The following is a description of a gene set: Genes up-regulated in comparison of dendritic cells (DC) stimulated with LPS (TLR4 agonist) at 0.5 h versus those stimulated at 12 h. Human Gene Set: GSE17721_0.5H_VS_12H_LPS_BMDC_UP mouse primary BMDCs were stimulated with tlr ligands and gene expression changes were profiled on Affymetrix arrays studied in species Homo sapiens from publication Amit I, Garber M, Chevrier N, Leite AP, Donner Y, Eisenhaure T, Guttman M, Grenier JK, Li W, Zuk O, Schubert LA, Birditt B, Shay T, Goren A, Zhang X, Smith Z, Deering R, McDonald RC, Cabili M, Bernstein BE, Rinn JL, Meissner A, Root DE, Hacohen N, Regev A (PMID 19729616), and this is the list of marker genes: C19orf48P, C15orf40, IFI30, TTYH2, CANX, ZFP91, TBC1D14, XPR1, SLF1, TK1, IGHM, TMEM147, PPP3CA (protein phosphatase 3 catalytic subunit alpha), HIGD2A, SCN11A, MED29, FKBP11, NFATC1 (NCBI Gene Id 4772), MYT1L, SORBS3, EHHADH, CENPV, MRPL3, HLA-DMA, GADD45GIP1, MRPL55, PIGK, PEMT, ATP5F1B, SEC61B, ELOVL5, GSC, METTL8, GPX4, FAM111A, HNRNPL, PELP1, CSRP2, FOXP1, THYN1, SAE1, SWSAP1, HSPA4, DDX3X, NUDT4, TESK2, GALK2, EEF1AKMT1, NXPH1, SCEL, KIFC1, FAM149B1, HCFC1, AIMP1, NAF1, DPH2, RPL35, ZFYVE21, PCNA, CMIP, MGAT2, CPA1, BDH1, BABAM1 (NCBI Gene Id 29086), NHP2, EMP1, FDPS, ANKRD54, LARP7, MRPS24, WDR6, GUSB, ASF1B (NCBI Gene Id 55723), MRPL23, OPN3, ZMPSTE24 (NCBI Gene Id 10269), SFSWAP, LARGE1, EEF1B2 (NCBI Gene Id 1933), MAPK3, TSPAN13, MMP12, MRC1, NHSL1, SASH3, ARHGDIB, NDUFA10, COA6, ATP5PF, PLA2G2A, CCR6 (NCBI Gene Id 1235), SLC50A1, MRPL36, IFT80, IL6ST, IRAG2, KIAA1143, CENPT, H2AX, HIP1, PYCR3, B3GNT8, CDKN2C, NOLC1, MDP1, RGS10, PCID2, ATP5IF1, PPP2R2D, ALDH18A1, ACO2, ATP5F1A, ZXDC, IPO4, RPL28, ABCD2, TRIM3, SLC25A13, NDUFAB1, MYORG, QTRT1, ZNF280D, SCAF8, KIAA0930, ACY1 (NCBI Gene Id 95), FUOM, ASB12, WNT5A, LCLAT1, TOMM40L, NDUFC2, STARD4, VDAC1, MYCBP2 (NCBI Gene Id 55685), TFEC, CDK1, GINS1, TECR, RTF2, TEC, ACTL6A, LSP1, ABCD1, FKBP4, CDK2AP1, HDGF, EMC8, MRAS (NCBI Gene Id 654181), H1-10, RAB31, GASK1B (NCBI Gene Id 83936), TAF10, GMPR, CYP4F3, CALML3, ACAT1, MATR3 (matrin 3), C6orf89, SF3B1, GPT, ALDOA, ARMC6, MRPS26, AKR7A2, TRIP11, ARPC4, CD8B, OTULIN, PMFBP1, HAUS8, SPN, KCNK13, S100A1, SLC26A6, NCOA1 (NCBI Gene Id 8648), FAM81A, TPRN, MRPL42, ATP6V0D1, UCHL5, HPRT1, NUCB2, LAPTM4B, LTBP3, IER2, PPP1CC, ENPP1, RPL19, ENC1, ELOVL7, GUCA1A, TNFRSF21, GSTZ1, SAP30BP, HM13, GOLM1, RPL13, DHX32